The following is a description of a gene set: studied in species Homo sapiens DNA replication. Human Gene Set: MODULE_158, and this is the list of marker genes: POLD1, TOPBP1, RRM2, RFC2, CHAF1B, HMGB1, SSBP1, CENPF, TENT4A, TERT, DDX11 (NCBI Gene Id 93260), GMNN, PRIM1, RFC3, CENPE, NAP1L1, RNASEH2A, RPA3, POLD2, POLE2, S100A11, PCNA, CDC45, ORC1, PRIM2, MCM3, BLM, FEN1, TOP2A, BRCA2, HMGB2, RFC5, POLE, CDK2, LIG1, RBBP4, POLA1, RRM1, RPA1, MCM6, RFC4 (NCBI Gene Id 5984), CDC7, CHAF1A